Given this list of marker genes IGHV4-39, IGLV3-12, IGLV2-18, MAPK8, IGHE, IGLV1-40, IGLV2-14, FOS, FCER1A, MAPK3, IGLV7-46, IGLV10-54, MAPK9, IGHV7-81, PLCG2, IGHV3-7, IGKV1-17, IGKV2-28, MAP2K7 (mitogen-activated protein kinase kinase 7), IGHV3-48, IGLV4-69, IGKV1-5, IGHV4-34, IGLV1-47, GRAP2, IGLC3, IGHV1-46, IGKV1D-39, JUN, IGLV7-43, IGLV2-8, IGKV5-2, IGLV3-27, IGHV3-33, IGLV4-3, VAV1, IGKV4-1, IGLV11-55, IGLV3-22, IGHV3-30, GRB2, IGHV3-9, IGKC, IGKV3-15, IGKV3-20, IGLV5-45, IGLV3-16, IGKV1D-16, IGLV1-44, IGLC6, IGLV6-57, IGHV2-70, IGLV3-21, MAP3K1, IGKV2D-40, MAPK10, IGHV2-5, IGLC2, IGHV, IGLV1-51, VAV2 (vav guanine nucleotide exchange factor 2), HRAS, IGKV1-39, SYK, IGLC1, IGKV3-11, MAP2K4, IGLV2-11, LYN, IGHV1-69, IGHV3-53, IGKV1D-33, IGLV2-23, IGKV2D-30, IGLV3-1, IGHV3-11, IGKV3D-20, IGHV1-2, IGHV4-59, IGLV5-37, IGKV1D-12, KRAS, LAT, FCER1G, IGLV3-25, MS4A2, IGLV4-60, IGLV2-33 (NCBI Gene Id 28811), IGKV1-33, NRAS, IGKV2-30, IGLV3-19, IGLC7, IGKV1-12, LCP2, PAK1, IGLV, PLCG1 (phospholipase C gamma 1), MAPK1, IGKV2D-28, SHC1, PAK2, IGLV1-36, IGKV1-16, IGHV3-13, VAV3, SOS1, IGHV3-23, RAC1, IGLV8-61, IGKV2-29, here is a description of the gene set: Reactome Pathway: FCERI mediated MAPK activation studied in species Homo sapiens Formation of the LAT signaling complex leads to activation of MAPK and production of cytokines. The sequence of events that leads from LAT to cytokine production has not been as clearly defined as the sequence that leads to degranulation. However, the pathways that lead to cytokine production require the guanine-nucleotide-exchange factors SOS and VAV that regulate GDP-GTP exchange of RAS. After its activation, RAS positively regulates the RAF-dependent pathway that leads to phosphorylation and, in part, activation of the mitogen-activated protein kinases (MAPKs) extracellular-signal-regulated kinase 1 (ERK1) and ERK2 (Gilfillan & Tkaczyk 2006). part of: Fc epsilon receptor (FCERI) signaling